The following is a description of a gene set: Mouse Gene Set: GOBP_DNA_TEMPLATED_TRANSCRIPTION_INITIATION The initial step of transcription, consisting of the assembly of the RNA polymerase preinitiation complex (PIC) at a gene promoter, as well as the formation of the first few bonds of the RNA transcript. Transcription initiation includes abortive initiation events, which occur when the first few nucleotides are repeatedly synthesized and then released, and ends when promoter clearance takes place. species: Mus musculus, and this is the list of marker genes: Sub1, Ep300, Med27 (NCBI Gene Id 98820), Ogg1, Setx, 4930402K13Rik (NCBI Gene Id 75775), Tet2, Rbbp5, Ikzf1, Atad2b, Bmyc, Med19, Atf2, Med25, Kmt2a, Ctnnbip1, Med21, Med20, Wbp2, Tbpl2, Thra, Med8, Gtf3c4 (NCBI Gene Id 99180), Polr1g (NCBI Gene Id 70333), Kdm1b, Med4, Gtf2a1l, Xpa, Med18, Lipe, Zfp473, Usp21, Gtf2h1, Smarcd1, Taf2, Tet3, Foxo1, Fam47e (NCBI Gene Id 631632), Zmpste24, Bclaf1, Med26, Taf1, Med12, Setd1a, Polr2g, Kat8, Taf1b, Fosl1, Taf11, Apex1, Ahr, Ercc2 (excision repair cross-complementing rodent repair deficiency, complementation group 2), Polr2d, Bdp1, Tbp, Taf5 (TATA-box binding protein associated factor 5), Pabpc1l, Znhit1, Egr1 (early growth response 1), Med29, Hnf1b, Cavin1, Dhx36, Eloc, Rrn3, Apobec2, Srf, Glyr1, Men1, Med28, Eloa, Polr1e (NCBI Gene Id 64424), Polr1f, Ctcfl, Sirt7, Tfb2m, Brf1, Nfkb1, Mir744, Atad2, Rsf1, Ercc3, Taf12, Ubtf, Ercc6, Macroh2a1, Mnat1, Tet1, Ercc1, Tbpl1, Polrmt, Kdm1a, Letmd1, Smarca5, Med11, Med23, Nfkbia, Cdk7, Polr2i, Taf4b, Ncoa6, Nr3c1, Maz, Med7, Nkx2-5, Med15, N6amt1, Polr3h, Mitf, Ttf1, Kat7, Tsix, Gtf2a2, Gtf2f1, Med22, Morc1, Med17, Brd7, Med30, Cand1, Gtf2a1, Tfam, Rbm14, Aicda, Myc, 4930480E11Rik, Med9, Wdr5, Taf3, Nfkbiz, Taf10, Cebpa, Taf8, Creb1, Taf9, Ftx, L3mbtl3, Jun, Taf13, Gtf2b (NCBI Gene Id 229906), Elob, Phf2, Twist1, Med10, Taf7, Med1, Gtf3c1, Gtf2e1, Med14, Trmt112, Gtf2f2, Myocd, Mterf1b, Tfb1m, Wnt10b, Spi1 (NCBI Gene Id 20375), Psmc6, Gtf3c5, Kdm2a, Gtf2e2, Vps72, Taf4, Taf1c, Med31, Trp53, Hnf1a (HNF1 homeobox A), Taf6l (TATA-box binding protein associated factor 6 like), Apobec1, Pou5f1, Smarca4, Taf9b, Paxip1, Dpy30, Sphk2, Med13, Taf6 (TATA-box binding protein associated factor 6), Brf2, Dr1, Padi2, Hey2, Samd1 (sterile alpha motif domain containing 1), Crcp, Ash2l, Pwwp2a, Med24, Med16, Lcor, Gtf2h5, Smarcb1, Ccnh, Fam47c, Esr1, Sgf29, Zfp451, Taf7l, Hmgb1, Snapc5, Med6